The following is a description of a gene set: The presence of a carcinoma of the esophagus. species: Homo sapiens Human Gene Set: HP_ESOPHAGEAL_CARCINOMA Esophageal carcinoma, and this is the list of marker genes: DLEC1, MSR1, LZTS1, TGFBR2, DCC (DCC netrin 1 receptor), RNF6, APC, STAT1, ASCC1, CTHRC1, WWOX, RHBDF2